The following is a description of a gene set: Human Gene Set: KIM_ALL_DISORDERS_DURATION_CORR_UP Cytoarchitectural abnormalities have been described in the prefrontal cortex of subjects with schizophrenia, bipolar disorder and depression. However, little is known about the gene expression profiles associated with these abnormalities. Genome-wide expression profiling technology provides an unbiased approach to identifying candidate genes and biological processes that may be associated with complex biological traits such as cytoarchitecture. In this study, we explored expression profiles associated with the abnormalities by using publicly available microarray metadata and cytoarchitectural data from post-mortem samples of the frontal cortex from 54 subjects (schizophrenia, n=14; bipolar disorder, n=13; depression, n=12 and controls n=15). Correlation analysis between genome-wide expression levels and cytoarchitectural traits revealed that genes were significantly correlated with a decrease in the number of perineuronal oligodendrocytes across all subjects. A total of genes were significantly correlated with a decrease in density of calbindin-positive interneurons across all subjects. Multiple biological processes including cellular metabolism, central nervous system development, cell motility and programmed cell death were significantly overrepresented in both correlated gene lists. These findings may provide novel insights into the molecular mechanisms that underlie the cytoarchitectural abnormalities of perineuronal oligodendrocytes and calbindin-containing GABAergic interneurons in the prefrontal cortex of the major psychiatric disorders. studied in species Homo sapiens Genes whose expression in brain significantly and positively correlated with the duration of all psychiatric disorders studied. from publication Kim S, Webster MJ (PMID 18762803), and this is the list of marker genes: RNF115, ANKRD11, ZBTB38, NTM, SHC3, SLC10A1, CSRNP3, DNAJB14, SPIN1 (NCBI Gene Id 95616)